Given this list of marker genes SNN (stannin), SPTY2D1, LMTK2, NFKBIZ, MAN2B2, GSAP, ZNF10, KRT73, CES5A, NOSIP, SLC26A11, H2BC15, FBXL5, SAMD4B, CHD9, MEGF6 (multiple EGF like domains 6), RNF139, SNX29, VCPKMT, TPRG1L, PTP4A1, YPEL5, EMC10 (NCBI Gene Id 284361), PTPRJ, IRS2, SOX4, PDE4B, STK19, LYRM9, FAM200B, TSPAN32, ARRDC3, ZDHHC11, ENSG00000284691, MEF2D, FAM83C, MAP4K4, ZNF329, USF3, ITPRIP, ASAH1, TENT5C, TENM1, SGK1, ITGA6, EMB, VPS9D1, ZNF805, LYZ, ZRANB1 (NCBI Gene Id 54764), SYNM, ENSG00000274253, VWA5A (von Willebrand factor A domain containing 5A), JUNB, YOD1, TXK, FBXO33, ST3GAL5, BMPR2, EFHC2 (NCBI Gene Id 80258), PCNT, VIPR1, TAS2R16, CD69, RASGRP2, LINC01138 (long intergenic non-protein coding RNA 1138), FBXO7, KLRB1, RNF125, PTPRM (protein tyrosine phosphatase receptor type M), ZXDB, HSD17B11, TNFSF8, PGAP3, SNORA28, EPHA4 (NCBI Gene Id 401031), ENSG00000291065, BIN2, EPB41L4A, PCIF1, MAP3K5, STXBP5, GABBR1, TPM2, GNAQ, TOX, ZIM2, MECOM, HABP4 (NCBI Gene Id 22927), TIGD1, ETV3, SUSD4, IL7R (interleukin 7 receptor), KLF3-AS1, EVI2B, IFT20, CUX1 (cut like homeobox 1), SNRPN, AQP3, DNAJC3, FNDC3B, NAAA, TP53INP1, AUTS2, ARHGAP21, ATXN1L, DPEP1, TRIB2, PARP8, GPATCH2, BMX, PLEK, SCARB2, DCUN1D2, TMX4, FAM8A1, ITGAM, AK5, PAIP1, TSIX, ST7, SKIL, TSPYL4 (NCBI Gene Id 92849), RBSN, DPEP2, APOBEC3A, DUSP1, SORL1, BTG2, DNAJB1, JADE1, MIR22HG, GPRASP2, FOS, ZNF423, ERO1B, RAP1GAP2, RNF10, SC5D, KLF2, CSGALNACT1, ENC1, GADD45A (growth arrest and DNA damage inducible alpha), G0S2, ANXA1, CNST, ASPH, IL11RA, PLXDC1, PIM1, ZNF8, OTUD1, WHAMM, LRRC27, YPEL2, MARCHF8, PRR12 (NCBI Gene Id 57479), CDC14A, PRKCQ, PTGS2, MARCHF2, NR4A2, TRAPPC10, KCNA3, CCDC66, ENSG00000280119, SOX6, ZNF256, COQ10A, DNAH5, ABHD13, SMCR5, SELL, CITED2, JMY, PELI2, WDR19 (NCBI Gene Id 80203), FYTTD1, PDCD4-AS1, GPRASP1, PDCL, TYROBP, RASA3, MORC2-AS1 (MORC2 antisense RNA 1), ATG14, RP9P, RNF11, UBL3, SLC2A11, KANSL2, KAT6A, ZNF592, here is a description of the gene set: Genes up-regulated in comparison of untreated CD4 T cells at 0 h versus the untreated cells at 48 h. Human Gene Set: GSE17974_0H_VS_48H_IN_VITRO_ACT_CD4_TCELL_UP species: Homo sapiens The aim of this dataset was to study in detail the transcription kinetics initiated by cytokine IL-4 in early differentiation of Th2 cells. from publication Elo LL, Järvenpää H, Tuomela S, Raghav S, Ahlfors H, Laurila K, Gupta B, Lund RJ, Tahvanainen J, Hawkins RD, Oresic M, Lähdesmäki H, Rasool O, Rao KV, Aittokallio T, Lahesmaa R (PMID 20620947)